The following is a description of a gene set: studied in species Mus musculus Mouse Gene Set: chr17A1, and this is the list of marker genes: Sytl3, Acat2, Ldhal6b, Gm15946, Nox3, Smok2b, 2700054A10Rik, Gm17748, Gm25119, Qki, T, 4930452A19Rik, Tagap1, Mir692-1, Plg, Gm17879, Mas1, Tcp1, Cep43, Gm24794, Tcp10a, 6530411M01Rik, Tmem181a, Gm6475, Gm41517, Gm15590, C030013G03Rik, Gm16574, Gm8363, Gm34883, Gm16168, Gm5491, Gm5479, Gm34035, Gm7162, Rps6ka2, Gm15425, Rsph3b, Dynlt1b, Gm11166, Gm8492, Smok4a, Tmem181b-ps, Dynlt1c, Gm16046, Pacrg, 1700122H20Rik, Gm4829, Gm8597, 3300005D01Rik, Tcp10b, Gm34799 (predicted gene, 34799), 4933426B08Rik, Tdgf1-ps2 (NCBI Gene Id 21669), Ccr6, Scaf8, Cldn20, Prkn, Slc22a1, Gm7043, Gm49221, Serac1, Rnaset2a, 4930506C21Rik (RIKEN cDNA 4930506C21 gene), Ppp1r2-ps1, Sft2d1, Ttll2, Gm26130 (predicted gene, 26130), Pde10a, Gm10231, Tfb1m, Unc93a2, Gm10232, 4930579D07Rik, Zdhhc14, Pnldc1, Gm5679, Acat3 (NCBI Gene Id 224530), Gm36684, Gm29719, T2, Slc22a3, 4732491K20Rik, Gm6618, 1700010I14Rik, Tcte2, Gm25909, Gm16169, Afdn, Gm24867, Rnaset2b, 1700102H20Rik, Gm2808, Gm28505, Slc22a2, Pisd-ps2, Tcp10c, Gm4828, Fndc1, 1700110C19Rik, C87487, Gtf2h5, Mrgprh, Wtap, Gpr31c, Tagap, Tiam2, Gm49958, Smok2a, Igf2r, Tmem242, Ppp1r2-ps6, Gm21926, Gm2792, Gm8376, Map3k4, Fbl-ps2, 4930470H14Rik, Gm7947, 4930517M08Rik, Gm1604a, Gm3355, Arid1b, Snx9, Mrpl18, Gm46593, Dynlt1a, Ezr, A230009B12Rik, Pabpc6, Gpr31a, Gm6553 (predicted gene 6553), Mpc1, Gm15599, Gm19283, Gm33086, Airn, Unc93a, Gm34684, Prr18, Gm10513, Tulp4, Synj2, Gpr31b, Dynlt1f, Sod2, Tmem181c-ps, Gm8603, Gm15426, Gm10512, Agpat4, 4930548J01Rik, Gm29721, Rsph3a, Gm17087, Gm3145, Gm46578, Snora20 (NCBI Gene Id 100303746), Gm29050